Given this list of marker genes Abl1, Nrp1, Cdc42, Shtn1, Rit2, Apoa1, Apoe (apolipoprotein E), Abca1, Was, Apoc3, Ntn1 (NCBI Gene Id 276903), Ralbp1, here is a description of the gene set: An intracellular signaling cassette in which a small monomeric GTPase of the Cdc42 subfamily relays a signal. studied in species Mus musculus Mouse Gene Set: GOBP_CDC42_PROTEIN_SIGNAL_TRANSDUCTION